Given this list of marker genes Fmo6, Fmo9, Fmo3, Fmo2, Gm4846, Fmo4, Fmo5, Fmo1, Gm4847, here is a description of the gene set: Catalysis of the reaction: N,N-dimethylaniline + NADPH + H+ + O2 = N,N-dimethylaniline N-oxide + NADP+ + H2O. Mouse Gene Set: GOMF_N_N_DIMETHYLANILINE_MONOOXYGENASE_ACTIVITY species: Mus musculus